The following is a description of a gene set: species: Mus musculus Mouse Gene Set: GOBP_TRANSLATIONAL_ELONGATION The successive addition of amino acid residues to a nascent polypeptide chain during protein biosynthesis., and this is the list of marker genes: mt-Th, mt-Tf, Mtrfr, Skic8 (SKI8 subunit of superkiller complex), mt-Tl1, Trnau1ap, Rchy1, mt-Tw, mt-Tq, Eef2, Nemf, mt-Te, mt-Tr, Eef1b2 (eukaryotic translation elongation factor 1 beta 2), Ufl1, Eef1a2, Rnf25, mt-Tl2, Eif5a2, Mrpl58, mt-Tm, Elac1, Eif4a3, Eif4a3l1, Sars1, Gtpbp2, Tufm, Eefsec, Gcn1, Skic3, Zfp598, Ascc2, Eef1d, mt-Tp, Saysd1 (NCBI Gene Id 74979), mt-Tk, Rplp2, Cdk5rap3, Mettl18, mt-Ts1, mt-Td, Pstk, Eif4a3l2, Eif4e2, Klhdc10, mt-Ti, Trip4, Usp10, mt-Ta, Ascc3, Smyd5, Pelo, Eef1a1, Abtb1, mt-Ts2, Secisbp2, Aars1, Rnf14, Gigyf2, Ddrgk1, Cpeb2, Mtres1, Hbs1l, mt-Tt, mt-Tn, Efl1, mt-Tc, Eef1g, Rplp1, Abce1, Gtpbp1, Rack1, mt-Tg, Eif5a (eukaryotic translation initiation factor 5A), Tsfm, mt-Tv, Mrpl44, Srp9, Ltn1, Gfm1, Usp16, Ptrh1, Sepsecs, Ufsp2, Shfl, Trnt1, Eef2k, Cpeb3, Alkbh1, Skic2, Tcf25, Ankzf1, mt-Ty